Given this list of marker genes NPTX2, IGF2, FGFR4, STC1, PMAIP1, ASPM, KIF20A, TOP2A, RRM2, CDK1, UBE2S, PCSK6, SLC2A6, MVK, NEK2, DTL, SQLE, PRC1, IL32, BARD1, PDE4B, MED8, here is a description of the gene set: species: Homo sapiens from publication West AN, Neale GA, Pounds S, Figueredo BC, Rodriguez Galindo C, Pianovski MA, Oliveira Filho AG, Malkin D, Lalli E, Ribeiro R, Zambetti GP (PMID 17234769) Human Gene Set: WEST_ADRENOCORTICAL_TUMOR_MARKERS_UP Pediatric adrenocortical tumors (ACT) are rare and often fatal malignancies; little is known regarding their etiology and biology. To provide additional insight into the nature of ACT, we determined the gene expression profiles of 24 pediatric tumors (five adenomas, 18 carcinomas, and one undetermined) and seven normal adrenal glands. Distinct patterns of gene expression, validated by quantitative real-time PCR and Western blot analysis, were identified that distinguish normal adrenal cortex from tumor. Differences in gene expression were also identified between adrenocortical adenomas and carcinomas. In addition, pediatric adrenocortical carcinomas were found to share similar patterns of gene expression when compared with those published for adult ACT. This study represents the first microarray analysis of childhood ACT. Our findings lay the groundwork for establishing gene expression profiles that may aid in the diagnosis and prognosis of pediatric ACT, and in the identification of signaling pathways that contribute to this disease. Top up-regulated genes in pediatric adrenocortical tumors (ACT) compared to the normal tissue.